Given this list of marker genes Atic, Ppat, Pfas, Paics (NCBI Gene Id 67054), Gart, Adsl, here is a description of the gene set: species: Mus musculus The chemical reactions and pathways resulting in the formation of IMP, inosine monophosphate, by the stepwise assembly of a purine ring on ribose 5-phosphate. Mouse Gene Set: GOBP_DE_NOVO_IMP_BIOSYNTHETIC_PROCESS